The following is a description of a gene set: Mouse Gene Set: GOBP_NEGATIVE_REGULATION_OF_RESPONSE_TO_BIOTIC_STIMULUS Any process that stops, prevents, or reduces the frequency, rate, or extent of a response to biotic stimulus. studied in species Mus musculus, and this is the list of marker genes: Inpp5d, Defb21, Mul1, Arrb2, Trafd1, Mill1, Atg12, Il4i1, Oas1b, Ifi207, Clec12b, Dhx58, Nlrp4a, Htra1 (NCBI Gene Id 56213), Igtp, H2-T23 (NCBI Gene Id 15040), Foxp3, Cep63, Rnf26rt, Serpinb9d, Ifi214, Sh2d1b2, Oas1g, Dcst1, Adar, Mavs, Mmp12, Ptpn6, Oas1a, Nt5c2, Fam3a, Sh2d1b1, Irak3, Klrd1, Ywhaz, Pparg, Ddx39a, Pim1, Nfkbil1, Arg1, Nectin4, Tnfaip3, Arg2, Tarbp2, Oas1e, Oas1f (2'-5' oligoadenylate synthetase 1F), Ltf, Ilrun, Pten, Ahr, Serpinb9f, Ifi208, Parp1, Ttll12, Trim38, Rps19, Acod1, Ifi213, Klre1, Mettl3, Banf1, Usp18, Clec2d, Atg5, Aurkb, Sirpa, Dusp10 (NCBI Gene Id 98270), Grn, Dnaja3 (NCBI Gene Id 98023), Trib1, Oas3, Trex1, Nlrp4c, Serpinb9c, Eif4e2, Nlrc5, Gigyf2, Sfn, Ifi203, Ins1, Susd4, Ythdf3, H2-M3, Prdx2, Lgals9, Oas1c, Nlrx1, Ceacam1, C1qbp, Ifi203-ps, Lyar, Ptpn2, Pdcd1, Ins2, Rnf26, Pcbp2, Mapkbp1, Ythdf2, Ppm1b, Cd274, Smim30, Tap1, Usp15, Serpinb9g, Tgfb1, Igf2, Samhd1, Muc4, Parp14, Nlrp4b, Vsig4 (NCBI Gene Id 278180), Cd96, Ccr1, Ufl1, Serpinb9b, Nlrp4e, Isg15, A2m, Ifi206, Klrb1b, Tap2, Smpdl3b, Stat2, Grb2, Cactin, Dtx4, Ifi209, Itch, Fgl2, Oas1d, Serping1, Nectin2, Serpinb9, Tyro3, Zdhhc18, Traf3ip1, Nlrp4f, Nmi, Irgm1, Trim21, Drd2, Mndal, Havcr2, Oas1h, Irgm2, Slamf8, Cnot7, Otop1, Serpinb9h, Nlrc3, Crk, Serpinb9e, Usp38, Gfer